Given this list of marker genes Tbx4, Apold1, Npy1r (NCBI Gene Id 18166), Kcnj11, Rora, Flvcr2, Inhba, Cdk1, Ppp1r16b, Atm, Prrx1, Abl2, Ism1, Prkx, Map3k3, Mir133a-2, Loxl2, Syk, Sp2, Col4a3, Prop1, Agtr1a, Id3, Sox9, Ryr2, Map3k7, C3ar1, Nkx2-5, Fuz, Oxt, Popdc2, Bmpr1a (bone morphogenetic protein receptor, type 1A), Ang2, Bmp2 (bone morphogenetic protein 2), Ube4b, Fam3d, Rxra, Sav1, Mylk3 (NCBI Gene Id 676159), Epha1, Hspg2, Mir24-2, Bsg (NCBI Gene Id 12215), Tnmd, Irx3, Nkx2-6, Pcdha8, Ncl, Il12b, Mir19a, Mical2, Fam114a1, Srpx2, Mmp13, Sh3pxd2b, Nr2e1, Lmna (NCBI Gene Id 16905), Vav2, Foxh1 (NCBI Gene Id 14106), Gja5, Ubp1, Cldn5, Dysf, Tead2, Bcam, Dhx36, Cxcr3, Rspo3, Dyrk1a, Nedd4 (NCBI Gene Id 639396), Dchs1, Agtr2, Tbx18, Pde3b, Foxp4, Cx3cr1, Trp73, Prkca, Mbd2, Dnaaf1, Il12a, Myod1, Smarca2, Tmem65, Nr4a1, Asb4, Ptk7 (PTK7 protein tyrosine kinase 7), Cad, Sars1, Sgcd, Tafa5, Ankrd17, Hdac2, Kdm2a, Clic4, Hgf, Ephb3, Bcor, Hmox1, Ednra, Cd34, Tfap2b, Slit2, Rb1cc1, Tgm2, Gpc3, Zfp418, Stra6, Tie1, Slitrk5, Pdlim3 (PDZ and LIM domain 3), Hamp2, Rbm10, Dhcr7, Wt1, Mapk11, Odad3, Mecom, Egfl7, Pdgfb, Mdm4, Agtr1b, Mia3, Prok2, Lox, Map2k1, Bbs7, Eif2ak3, Smyd1 (NCBI Gene Id 97290), Ptgis, Tbx2, Efemp2, Fhl2, Tgfb2, Ptk2, Pdlim4, Tnf, Chd7, Ptk2b, Acvr1b, Tsc1, Slit3, Gnaq, Ccdc40, Adrb1, Apln, Acan, Slc8a1, Casp7, Btg1, Sash1, Eva1a, Tbx20, Fgf8, Efna3, Lepr (NCBI Gene Id 16847), Mapk1, Ttn (NCBI Gene Id 99250), Anpep, Ccn2, Pxn (NCBI Gene Id 19303), Mylk2, Snai1, Plcg1, Sox6, Rras, Aggf1, Nf1, Anxa2 (annexin A2), Itga2b, Erbb3, Jmjd6, Smad7, Thbs4, Anks6, Krit1, Scx, Pkm, Rbm15, Pdlim7, Tgfbr3, Lama1 (NCBI Gene Id 16772), Efna1, Pin1rt1, Ywhaz, Ift20, Ccdc134, Ndufv2, Sfrp2, Htr2b, Uts2r, Cimap3, Tgfbr2, Ndnf, Scn11a, Yap1, Gaa, Tbx5, Mbd3 (methyl-CpG binding domain protein 3), Itga5, Akap13, Agt, Serpinf2, Nipbl, Cdkn1b, Mmrn1, Dcn (decorin), Sgcz, Clic3, Slc25a4 (NCBI Gene Id 11739), Fzd8, Gpx1 (NCBI Gene Id 14775), Cxcr2, Alox5, Mir27a, Sgpl1, Atp5f1b, Foxn1, Thbs2, Bmpr2, Alpk3, Zmpste24, Adam8, Jag1, Foxl1, Gng5, Atp2b4, Slc39a12, Hyal1, S2bpcox16, Ramp2, Stk3, Gata6, Bmp10 (bone morphogenetic protein 10), Pdcd10, Synj2bp, Col1a2, Gys1, Tek, Col11a1, Igf2, Gpr15, Smad5, Gadd45a, Ephb1, Flvcr1, Pax3, Nrarp, Hoxb3, Itgb1, Ccl5, Col18a1, Prkar1a, Micall1, Adgrb1, Pou4f1, Prickle1, Enpp1, Emc10, Bves (blood vessel epicardial substance), Gli1, Angptl4, Wdpcp, Mrtfb, Robo1, Adamts1, Crkl, Oxtr, Ltbp1, Arl13b, Uts2, Ramp1, Sorbs2, Esx1 (NCBI Gene Id 13984), Tsc2, Rock2, Ngp, Igf1, Plxna4, Minar2, Atg7, Lgals3, Abcc8, Vegfa, Lrg1 (leucine-rich alpha-2-glycoprotein 1), 2810429I04Rik, Mmp21, Pdpn (NCBI Gene Id 14726), Tnnt2, Gna11, Fgfbp1, Cxcl17, Pf4, Rnf213, Ctdp1, Vegfc, Ptpn6, Dicer1, Fzd7, Spint1, Angptl7, Sox17, Col1a1, Hs6st1, Cdx2, Svep1, Tnfrsf12a, Socs3, Ift25, Chi3l1, Ldb3, Col5a1, C2cd3, Rxrb, Gata3, Rtn4, Jup, Ccl11, Fgf15, Slc2a12, Prkcb, Drc1, Pde2a, Zmiz1, Dvl1, Smad4 (NCBI Gene Id 28063), Fgfr2, Pi16, Smyd2, Foxj1, Ift88, Pcnt, Serpinf1, Map2k3, Setd2, Dlx3, Myh11, Fgf10, Aqp1, Npr2, Sod2, Ldlr, Cc2d2a, Acta2, Fgf2, Rnls, Pbrm1, Smo, Edn1, Fgfrl1, Fgf1, Epas1, Grhl2, Rarb, Insr, Scn5a, Hoxa5, Gpld1, Tmem100, Shox2, Heg1, Fap, Myh9, Kdm6b, Hhipl1, Unc5b, Pank2, Plec, E2f7, Ccr2, Notch1, Sirt1, Gja6, Mmp19, Egf, Megf8 (multiple EGF-like-domains 8), Gata5, Epor, Dnai1, Cfh, Prkd2 (NCBI Gene Id 232912), Ift122, Hspb6, Cluap1, Dzip1, Pdgfa (platelet derived growth factor, alpha), Rbm20, Zfp950, Mir17, Nrcam, Nfe2, Gsk3a, Rps6ka2, Vegfb, Col8a1, Ang, Adgrf4, Crhr2 (NCBI Gene Id 12922), Gata4, Plxnd1, Hpgd, Fgf18, Dusp6, Bmper, Adamts19, Pecam1, Arhgap24, Ephb2, Chrd, Ep300, Plcd3, Calcrl, Cdc42, Eln, Myh6, Klf2, Tbc1d32, Lemd3, Tgfbr1, Erbb4, Akt3, Asb2, Itgb3, Hk2, Has2, Ift57 (intraflagellar transport 57), Lcn10, Hspb7, Wnt5a, Grn, Cd59a, Wnt3a, Naxe, Mir452, Emcn, Vgll4, Bcas3, Sema5a, Hif3a, Immp2l, Llgl2, Mib1, C5ar1 (NCBI Gene Id 12273), Cav1, Myh10 (myosin, heavy polypeptide 10, non-muscle), Vangl2, Card10, Foxs1, Arhgap22, Adra1b, Pax6, Acvrl1, Klk1b1, Sgcg, Ndrg4, Foxn4, Ptpn14, Gm12610, Cemip2, Stat3, Nek8, Gm572, Jarid2, Cnmd, Cdx4, Olfm1, Ppara, Zdhhc16, Pdcd6, Tcf21, Epn1, Gatad2a, Gbx2, Nus1, Fhod3, Adamts6, Zbtb14, Tspan12, Eef1ece2, Pln, Med1, Kcnj1, Traf3ip2, Ggnbp2, Flt1, Ptprj, Dctn5, Chm, Or10j5, Sirt6, Mesp2, Serpine1, Tgfbi, Adtrp, Ccbe1, Wars1, Tgfb1, Prox1, Tcf7l2, Foxj2, Adgrb2, Shc1, Med12, Tnfsf4, Hey2, Prokr1, Bmp5, Zfand5, Gpr4, Cfc1, Anp32b, Sox4, Tab1, Pgk1, Otulin, Nrp2, Optc, Dvl3, Tmem94, Id2, Rgcc, Spry1, Nox1, Pik3r2, Yjefn3, Ccl12, Gtf2i, Snai2, Pdgfd (platelet-derived growth factor, D polypeptide), Mtdh, Pnpla6, Fkbp10, Ctsh, Ovol2, Gli2, Wnt2, Mosmo, Notch2, Pcna, Dnm2, Sparc, Akt1, Prickle4, Tnni3, Lrp2, Ghsr, Efnb2, Cysltr2, Id1, Cx3cl1, Stil, Cela1, Tert, Lemd2, Smoc2, Tnfsf12, Gper1, Nat8f5, Adam19, Sulf1, Tmem67, Mmp9, Mthfd1, Nsd2, Serpinb7, Nodal, Tbx1, Apoh, Paxip1 (PAX interacting (with transcription-activation domain) protein 1), Slc1a1, Heyl, Htatip2, Mir145a, Dnmt1, Ppard (peroxisome proliferator activator receptor delta), Traf3ip1, Rbm24, Ift172, Kif3a, Rhoj, Ift74, Trip11, Amotl2, Nebl, Tspan18, Cer1, Rom1, Ncam1, Adm, Kit, Invs, Osr1, Sufu, S100a1, Itgb2l, Cplane2, Prkdc, Col4a2, Ccl2, Hoxa13, Nfatc2, Nppb, Adam10, Pcsk5, Actg1, Fzd4, Tgfa, Hdac7, Mcam, Mir23a, Slc4a7 (solute carrier family 4, sodium bicarbonate cotransporter, member 7), Epha2, Fgf3, Minar1, Robo4, Smad3, Tcap, Fkbpl, Pdlim2, Vash1, Pkd2, Tnn (tenascin N), Ccm2, Dag1, Tnni1 (troponin I, skeletal, slow 1), Map2k2, Rasa1, Pik3c2a (NCBI Gene Id 18704), Xbp1, Foxo4, Ccn1, Ptcd2, Becn1 (beclin 1, autophagy related), Ccn6, Naglu, Mmrn2, Nxn, Foxo1, Fkbp1a, Dlc1, Elk3 (ELK3, member of ETS oncogene family), Cspg4, Fgfr1, Vash2, Zic3, Ntrk3, Flrt2, Dipk2a, Pik3cg, Pik3ca, Sgcb, Hand2os1, Bmp7, Zc3h12a, Ifitm2, Ap1b1, Hand1, Myl3, Pdgfra, Ift140, Mir19b-1, Acvr2b, Fasl, Axin2, Pacsin2, Acadm, Rgs4, Mir208a, Mef2b, Ninj1, Amot, Mmp14, Psen1, Cripto, Angpt1, Pax8, Apela, Shh, Casp8, Hamp, Ahr, Hpse, Mir218-1, Ang6, Pin1, Tfap2a, Pdlim5, Rapgef1, Rasip1, Rela, Kcnq1, Sec1, Mir329, Acvr1, Matr3, Atf2, C1galt1, Mybpc3, C3, Wnk1, Kcnk2, Smarca4, Ap2b1, Trex1, Tmed2, Jph2, Anxa1, Flna, Ppp3r1, Vps4b, Xdh, Asxl1, Ptpn11, Hif1a, Flt4, Mgrn1, Mir1a-2, Cd36, Brpf1, Wnt7b, Fyn, Uty, E2f8, Lrp5, Emilin1, Nrxn3, Npr3, Kif7, Grem1, Twist1, Jun, Bicc1, Atf7, Sall1, Wasf2, Vcam1, Tpm1, Smad1, Plau, Mir18, Ncor2, Ngfr, Itgax, Ift52, Etv2, Pak1, Sox18, S1pr1, Setdb2, Nrap, Spry2, Sp100, Nsdhl, Lmo4, Mef2d, Add1, Lep, Glmn, Tomm70a, Frs2 (NCBI Gene Id 327826), Ryr1, Hes1, Il18, Ereg, Tbx3, Mir27b, Vstm4, Lrp6, E2f2, Myh7, Abcc9, Hexim1, Cth, Erap1 (NCBI Gene Id 80898), Nrxn1, Vezf1, Hand2, Nphp3, Tjp1, Bak1, Zfpm2, Reck, Ank2, Klf5, Adgrf5, Wdr83, Sema3e, Itgb1bp1, Hey1, Cep290, Eomes, Ext1, Epn2, Fgf6, Xirp2, Col2a1, Dll4, Bax, Fgf9, Parva, Jak1, Robo2, Stat1, Nrp1, Ceacam1, Cited1 (Cbp/p300-interacting transactivator with Glu/Asp-rich carboxy-terminal domain 1), Myo18b, Popdc3 (NCBI Gene Id 78977), Mnat1, Atp7a, Sema3c, Rapgef2, Ackr3, Mapk3, AW551984, Lgals8, Il17f, Nkx3-1, Mtor, Hc, Cacybp, Lama4, Nras, Enpep, Antxr1, Rin2, Mir143, Arrb2, Stim1, Sema6a, Plpp3, Rbpj, Stard13, Cited2, Msx2, Prdm1, Ang5, Cavin4, Prkg1, Lef1, Hnrnpu, Angpt4, Lefty1, Cd47, Gla, Isl1 (ISL1 transcription factor, LIM/homeodomain), Lbx1, Smarcd3, Pou4f2, Stk4 (NCBI Gene Id 99242), Wnt4, Plg, Cntrl, Dsp, Dab2ip, Dand5, Itgav, Met, Runx1, Tbxa2r (thromboxane A2 receptor), Pml, Irx4, Lif, Kat2b, Tnfrsf1a, Prl2c2, Rgs2, Ccm2l, Hmgb1, Sox11, Pdlim1 (PDZ and LIM domain 1 (elfin)), Dkk1, Spi1, Tmem201, Mesp1, Prkd1, Rhob, Ntrk1, Cxadr, Klf4, Fes, Rbp4, Mir126b (NCBI Gene Id 102465787), Aplnr, Dnah5, Sphk2, Egr2, Adm2, Trp53bp2, Rac1, Pik3cd, Aimp1, Ccnd2, Itgb2, Nppc, Smyd4, Grk2, Hhex, Ankrd1, B9d1, Mir23b, Slc9a1, Adprhl1, Thsd7a, Cfd, Csrp3, Cert1, Cyp1b1, Pdgfrb, Spred1, Cplane1, Wars2, Foxc2, Senp2, Arid1a, Slc12a2, Hoxa3, Pik3r6, Pskh1, Emp2, Mterf4 (mitochondrial transcription termination factor 4), Apc, Trp53, Ndst1, Mks1, Rock1, Comt, Sphk1, G6pd2, Lrrc10, Pparg, Pak4, Gata2, Cd40, Adap2, Large1, Cib1, Rnf207, Ascl1, Mir92-1, Slc2a10, Parp2, Pdcd4, Hipk2, Sp1, Apoe, Sh2b3, Angptl3, Adrb2, Thy1, Cma1, Rest, Odad2, Col14a1 (NCBI Gene Id 70486), Jcad, Hdac3, Pknox1, Ppp3cb (NCBI Gene Id 66215), Prrx2, Ntrk2, Gab1, Daw1, Hoxa7, Itgb8, Snx17, Egln1, Ago1, Asxl2, Lipa, Prok1, Pkd1, Th, Notch3, Ubiad1, Ctnnb1, Prcp, Adipor2, Folr1 (folate receptor alpha), Scg2, Meox2 (NCBI Gene Id 17286), Dnaaf4, Dhrs3, Tnfaip2, Foxf1, Fadd, Npy5r, Vegfd, Ctcf, Ptgs2, Ptprm, Ccn4, Luzp1, Galnt11, Col3a1, H2-M3, Prmt1, Ephb4, Adgrb3, Anxa3, Psg22, Mir24-1, Borcs8, Ago2 (NCBI Gene Id 70188), Creb1 (NCBI Gene Id 98624), Aldh1a2, Nrg1, Mir20a, Cdh2, Pitx2, Adam15, Bvht, Egr1, Rapgef3, Pkp2, Il1b, Ptn, Ghrl, T, Neb, Sin3b, Pofut1, Pdpk1, Zfp36l1, Mir218-2, Jam3, Egfl8, Hbegf, Myo1e, Tcf4, Ecm1, Hoxb13, Bmp4 (bone morphogenetic protein 4), Epgn, F3, Fbn1, Frem2, Tab2, Fut1, Slc22a5, Fbln5, Dsg2, Adra1a, Ly6e, Synb, Col8a2, Nfatc1, Nr3c1, Brca1, Vav3, Actc1, Ecscr, Tnfrsf1b, Itga3, 3425401B19Rik, Srf, Ihh (Indian hedgehog), Foxc1, Nfatc3, Hopx, Flrt3, Cav3, Mb, Alpk2, Plcd1, Tead1, Arid2, Trip10, Ccn3, Dnaaf3, Ric8a, Fkrp, Gja4 (gap junction protein, alpha 4), Fdps, Glul, Camk2d, Col4a1, Rpgrip1l, Ncoa6, Epo, Mir133a-1, Greb1l, Casp3, Myl7, B4galt1, Cd160, Msx1, Pdcl3, Fat4, Junb, Jmjd8 (jumonji domain containing 8), Noto, Tiparp, Tbx19, Lix1l, Mapk14, Six1, Adgra2, Egfr, Kat2a, Mef2a (myocyte enhancer factor 2A), Fgf20, Hgs, Wnt11, Ppp1r15a, Eng, Tal1, Wnt7a, Pkd1l1, Pik3r3, Fosl1, Zfpm1, Sos1, Srpk2, Apob, Foxp1, Rap1a, Tmem204, Gm28729, Adgrg1, Pxdn, Ppp1r13l, Ctnnd1, Poglut1, Lyl1, Mmp2, Plk2, Mir1954, Hdac9, Nprl3, Calr, Fzd5, Wdr11, Lrp1, Cdh13, Cybb, Mexis, Mylk, Sik1, Erbb2, Notch4, Foxm1, Naa15, Cdh5, Ccdc103, Tmem215, Hspb1, Hspa12b (NCBI Gene Id 72630), Nog, Sema4a, G6pdx, Itga4, Mapk7, Gli3, Cdkn1a, Tnnc1, Ccr3, Creb3l1, Cflar, Nfe2l2, Thbs1, Gjc1, Mef2c, Vhl, Fbxw8, Tgfb3, Epha3, Ccl24, Pten, Col6a1, Meis3, Speg, Kdm6a, Adamts9, Mdm2, Esm1, Ndp, Cacna1c, Il1a, Ptprb, Meis1, Nox4, Errfi1, Adamts5, Gdf2, Hhip, Maml1, Sec24b, Nckap1 (NCK-associated protein 1), Gja1, Adam12, Dnah11, Rhoa, Synpo2l, Ang4, Rara, Smg9, Pik3cb, Mixl1, Kdr, Gsk3b, Arhgef15, Ankrd11, Kctd10, Lrrc25, Tlr3, Ddah1, Wnt16 (wingless-type MMTV integration site family, member 16), Fn1, Sall4, Adgrg6, Ndufs6, Syde1, Ptger4, Pcdha9, Itga7, Npy2r, Cby1, Mecp2, Pim1, Ptch1, Ski, Hmga1, Zfp354c, Mfge8, Fzd2, Egr3, Ddit3, Pds5a, Epc1, Eya1, Shb, Abl1, Ptpn20, Ripply3, Emilin2, Comp (NCBI Gene Id 12845), Hdac5, Ece1, Acacb, Nfatc4, Crb2, Dync2h1, Tenm4, Pgf, Gna13, Mydgf, Edn2, Akap6, Myocd, Rnh1, Cul7, Cysltr1, Myl2, Camp, Hrg, Adra2b, Qki, Rtl1, Nr2f2, Fzd1, Nfix, Yy1, Ilk, Dll1, Hmga2, Stk11, Clec14a (C-type lectin domain family 14, member a, NCBI Gene Id 66864), Dvl2, Ets1, Cxcr4, Nos3, Fmnl3, Rb1, Cpe, Slc31a1, Ehd4, Prl7d1, Amotl1, Cd93 (CD93 antigen), Il10, Kcnj8, Vcan, Sypl2, Kat6a, Cxcl12, Hoxa1, Ifng, Odad4, Stab1 (stabilin 1), Mdk, Atg5, Fbxw7, Txnrd2, Ace, Hectd1, Xirp1, Il6ra, Smad2, Tmem231, Angpt2, Map2k4, Cxcl10, Angptl6, Ddx39b, Actn2, Mospd3, Tafazzin (NCBI Gene Id 78810), Map2k5, Ccnb1, Ccdc39, Smad6, here is a description of the gene set: Mouse Gene Set: GOBP_CIRCULATORY_SYSTEM_DEVELOPMENT The process whose specific outcome is the progression of the circulatory system over time, from its formation to the mature structure. The circulatory system is the organ system that passes nutrients (such as amino acids and electrolytes), gases, hormones, blood cells, etc. to and from cells in the body to help fight diseases and help stabilize body temperature and pH to maintain homeostasis. species: Mus musculus